The following is a description of a gene set: The process whose specific outcome is the progression of the thyroid gland over time, from its formation to the mature structure. The thyroid gland is an endoderm-derived gland that produces thyroid hormone. studied in species Mus musculus Mouse Gene Set: GOBP_THYROID_GLAND_DEVELOPMENT, and this is the list of marker genes: Thra, Hoxa3, Fgf8, Tg, Pax8, Six1, Tbx1, Hipk2, Duox2, Tubb1, Nkx2-1, Hoxb3, Nkx2-5, Raf1, Ctns, Braf, Ednra (endothelin receptor type A), Fgf10, Mapk3, Hmga1, Hhex, Rap1gap, Map2k1, Hesx1, Smad3, Hoxd3, Foxe1, Cga (NCBI Gene Id 12640), Srf, Map2k2, Mapk1, Edn1, Hoxa5 (NCBI Gene Id 15402), Six3, Shh